The following is a description of a gene set: part of: Cell death signalling via NRAGE, NRIF and NADE NADE protein (p75NTR-associated cell death executor) may induce cell death upon NGF binding, but not BDNF, NT3, or NT4/5 binding, to p75NTR. The NADE-dependent apoptosis is modulated by the 14-3-3-epsilon protein (Kimura MT et al, 2001). species: Homo sapiens Reactome Pathway: NADE modulates death signalling, and this is the list of marker genes: BEX3, NGF, CASP3, YWHAE, NGFR, CASP2